The following is a description of a gene set: species: Homo sapiens Human Gene Set: REACTOME_BIOSYNTHESIS_OF_LIPOXINS_LX Biosynthesis of Lipoxins (LX), and this is the list of marker genes: HPGD, LTC4S, ALOX12, PTGR1, ALOX5, ALOX5AP